Given this list of marker genes SH2D5, OXTR, ADRB2, FSTL3, TNFAIP3, PKP2, TK1, GFRA1, DKK1, AOX1, WWC2, WWC1, EPAS1, KRT80, MPP4, ZNF367, IL7R, NUAK2 (NUAK family kinase 2), DIAPH3, PRKAG2, FOSL1, CYTH3, GADD45B, ABL2, IL11, SLC8A1, SFTA1P, FJX1, ETS1, LAMC2, NAV3, RNF144B, VGLL3, ACAT2, CPA4, MPP7, PAWR, LETM2, ITGB2, RGS7, EPG5, SGMS2, DLC1, MFAP5, DDAH1, AXL, EPB41L4B, CCN1, ELL2, NPPB, ADAMTS6, RAB3B, TUBB6 (tubulin beta 6 class V), CRIM1, MB21D2 (Mab-21 domain containing 2), HBEGF (heparin binding EGF like growth factor), TGM2, CEP55, EPHA2, IL12A, RAPH1, GADD45A, CLDN1, RFTN1, ANLN, COL12A1, F3, KRT81, ANXA2, ANKRD1 (NCBI Gene Id 27063), C12orf75, SMURF2, NLRP3 (NCBI Gene Id 9558), TEAD4, GNGT2 (G protein subunit gamma transducin 2), CCN2, CNN3, ESM1, PCLO, here is a description of the gene set: species: Homo sapiens The YAP/TAZ-TEAD axis is activated and plays a causal role in several cancer types, and inhibitors that target this axis are currently in early phase clinical trials in cancer patients. However, mutations that predict YAP/TAZ-TEAD activation are not common in most cancers, making it hard to determine which tumors are likely to respond to these inhibitors. Here, we used a combination of RNA-seq and bioinformatics analysis of metastatic human melanoma cells to develop a YAP/TAZ gene signature. We found that the genes in this signature are TEAD-dependent in several melanoma cell lines, and that their expression strongly correlates with established YAP/TAZ target genes in human melanomas. Using DepMap dependency data, we found that the genes in this YAP/TAZ signature are highly expressed in YAP/TAZ or TEAD dependent melanoma cell lines and that this signature was predictive of melanoma cell dependence upon YAP/TAZ or TEADs. Importantly, this was not limited to melanoma because these genes are also regulated by YAP and TAZ in other cancer cell lines and this signature was predictive of YAP/TAZ-TEAD dependence when tested on a panel of over 1000 cancer cell lines. Our results suggest that this YAP/TAZ gene signature may be an effective tool to predict YAP/TAZ activation in cancer cells and could potentially be used to predict sensitivity to YAP/TAZ-TEAD inhibition. Human Gene Set: KANAI_YAP_TAZ_UP A set of genes that are up-regulated by YAP or TAZ in cancer cells and that are enriched in cancer cell lines that are dependent upon either YAP, TAZ or TEADs for cell viability. from publication Kanai R, Norton E, Stern P, Hynes RO, Lamar JM (PMID 38473214)